The following is a description of a gene set: Human Gene Set: CRX_Q4 Genes having at least one occurrence of the motif YNNNTAATCYCMN in the regions spanning 4 kb centered on their transcription starting sites. This matches the CRX transcription factor binding site V$CRX_Q4 (v7.4 TRANSFAC). studied in species Homo sapiens, and this is the list of marker genes: FGF14, NCOA2, NKX6-1, HR, RBM39, DIP2B (disco interacting protein 2 homolog B), FGF7, NR1H4, DCTN1, HOXD10, ETV5, KCNH2, MYO3B, ZNF384, WNT6, CLASP1, SPTSSB, C5 (NCBI Gene Id 727), SYNE1, BTRC, KCNIP2, CYP2F1, NR2F1, ZBTB18 (NCBI Gene Id 10472), KRT24, NRXN3, TENM3-AS1, SAMD11, RIMS1, H4C3, MOCOS, GPX1, E2F3, FIBCD1, TRIP10, DPYD, LDB2, AGA, CHD2, ENTPD1, TEX2, DLC1, UPRT, DMD, CTBP2, SOAT2, HOXC6 (homeobox C6), USP34, TLX3, MN1, MIER1, ESM1, CKMT1B, LIFR, BDKRB1, MCTP2, LINC01565, TIGD2, ERBB4, CLDN2 (claudin 2), RPS6KA3, NR6A1, CACNA2D4, TCF7L2, H1-2, POU6F2, NOTCH2, EGFL6, GRID2, GJD2, TLE4, POLD4, ERG, DALRD3, DSG4, UBXN10, FOXG1, BMI1, PROK2, ASCL4, SIX3, KRT2, TRIML1, LIN28A, ANGPTL2, SLC6A20, PCSK1, ITPRID1, LEMD1, C6orf62, MIP, MBD6, CDK2AP2, LTBP1, SATB1, MEOX2, SST, INTS12, FZD4, DMPK, SOX15, SLC12A5, TCF7, SSBP2, ZBTB4, MEIS1, MOAP1, PNPLA3, PTMS, TMUB2, PRRX1, CRYGS, ATP1B3, TNFSF11, RORA, DEF6, FOXB1, GNB3, MSH5, GLRA1, AKIRIN2, FRMPD2, PRKAG1 (protein kinase AMP-activated non-catalytic subunit gamma 1), HOXB3, KHSRP, DAP, MTCL2, ADGRL2, ATRNL1 (attractin like 1), ACKR3, TKT, TSC22D1, NAA60, RTN2, MAB21L1, SLITRK1, ETS2, CLMP, PAX6, TYRP1, CYRIB (NCBI Gene Id 51571), PURA, MAML3, NLGN1, HOATZ, HRK, ABCC6, LMO3, EFHB, EFS, TNFSF4, GRIN2B, CARTPT, MERTK, ZNF385A, ESRRG, DNAI4, NR2E1, EYA4, ABI3BP, RAB33A, TMEM126B, PITX2, IRX5, TULP1, ANXA11, SATB2, PGF, ID2, LYPD2, GDF7, ZFP36L2, FNDC9, C12orf50, FLRT1, PABIR1, CDKN2C, DMRT2, JARID2, DLG4, CNTLN (centlein), NIPBL, LLGL2, NOTCH2NLA, PCDHGC3, SARNP, BNC2, ARHGAP35, LRRTM4, FLNC, POLR2A, GSTCD, HMGN2, CNOT4, ATP6V0A4 (ATPase H+ transporting V0 subunit a4), CLUH, ABLIM1, HOXA3, VASP (vasodilator stimulated phosphoprotein), CAMK2A, AMHR2, EGFLAM, PPM1N, ROBO3, SLC5A2, TRMT10A, SLC13A4, CYTH2, CREB5, NDUFAF3, GAP43, UBAP2L, RAX, WNT3A, MTMR10, C10orf71, MED13, PITX1, RPRML, NEO1, KRT4, ZBTB20, FOXA1, PDE4D, MEPCE, ECHDC2, GUCY2F, CHORDC1 (cysteine and histidine rich domain containing 1), HOXC4, AMER1, PAX7, MDGA1, NFIX, HOXC5, HNF1A, AMMECR1, JMJD1C, PRDM13, LRIT1, CPEB4, OTOP3, RUNX3, ZNF281, ACADVL, RALGPS2, GPBP1, NOL4L, STAT5B, SRPK2 (SRSF protein kinase 2), SLC1A7, NOS1, CFB, BCL11A, IGSF3, GUCY2D, KRT3, ZPBP2, VXN, SLC6A5, AJUBA, GPR21, SLC9B2, BHLHE22, TNNT1, TMEM35A, BTG4, ACAA2, RPA3, ADAMTSL1, MSX2, KRTAP13-3, KCNA1, CASK, B3GALT5-AS1